The following is a description of a gene set: Human Gene Set: REACTOME_ALK_MUTANTS_BIND_TKIS species: Homo sapiens ALK mutants bind TKIs, and this is the list of marker genes: HIP1, BCL11A, FN1, EIF2AK3, PRKAR1A, BIRC6, PPM1B, NPM1, EML4, STRN, ALK, CLTC